The following is a description of a gene set: Mouse Gene Set: GOCC_CIS_GOLGI_NETWORK The network of interconnected tubular and cisternal structures located at the convex side of the Golgi apparatus, which abuts the endoplasmic reticulum. studied in species Mus musculus, and this is the list of marker genes: H2-K1, Pmel, Trappc6b, Angel1, Rab29, Man2a1, Bcl9, Mppe1, Trappc6a (trafficking protein particle complex 6A), Rab30, Azin2, Gbf1, Scyl1 (NCBI Gene Id 98159), Retreg1, Phtf1, H2-Q6 (histocompatibility 2, Q region locus 6), Fktn, Hook3, Kdelr3, Trip11, Cog3 (component of oligomeric golgi complex 3), H2-Q7, Sec23ip, H2-M10.6, Atp2c1, Gosr1, Yipf7, Akap9, Golgb1, H2-Q1, Pik3r1, Kdelr1, Map6, H2-M2, H2-Q10, Map6d1, Tmem165, Trappc3l, Rab3gap1 (RAB3 GTPase activating protein subunit 1), H2-Q2, Trappc3, Rnf183, H2-M3 (histocompatibility 2, M region locus 3), Slc35c2, Pcnt, B3gat3, H2-M10.1, Ift20, H2-M5, Ubxn2a, Tmed10, H2-T22, Bok, H2-M10.4, Vps13b, Tmed5, Rab18, Yipf6, Golga2, Kdelr2, Scfd1, H2-D1, Slc10a7, Lrpap1, H2-M11 (NCBI Gene Id 224754), Bet1, Golga5, Limk2, H2-M10.2, Gpr108